The following is a description of a gene set: from publication Chen Y, Wang X (PMID 31504780) Mouse Gene Set: MIR_8114 Genes predicted to be targets of miRBase v22 microRNA mmu_miR_8114 in miRDB v6.0 with MirTarget v4 prediction scores > 80 (high confidence targets). studied in species Mus musculus, and this is the list of marker genes: Recql, Clrn1, Crnkl1, Rbm33, Cadm2 (cell adhesion molecule 2), Tceanc2, Pmp22, Ubqln1, Gas7, Lrpap1, Otx2, Idh3b, Scel, Clptm1, Chtf8, Unc93a, Gpatch11, Hgf, Ada, Paqr8, Xxylt1, Cbr4, Cdc37l1, Dab1, Itga8, Fmnl2, Strbp, Mdga1, Ccdc68, Cyp26b1, Tnk1 (NCBI Gene Id 83813), Cdyl, Slc4a8, Mgat4a, Smad5, Dus4l, Smad7, Csmd3, Chordc1, Fam228b, Slco3a1, Kctd10, Nufip2, Ube3c, Zfp641, Zmym4